Given this list of marker genes Tnf, Ngfr, Tnfrsf10b, Ngf, Tnfrsf11a, Eda2r, Fas, Tnfrsf18, Tnfrsf4 (tumor necrosis factor receptor superfamily, member 4), Nradd, Eda, Tnfrsf1a, Hspa1a, Tnfrsf1b, here is a description of the gene set: species: Mus musculus Mouse Gene Set: GOMF_DEATH_RECEPTOR_ACTIVITY Combining with an extracellular messenger (called a death ligand), and transmitting the signal from one side of the plasma membrane to the other to initiate apoptotic or necrotic cell death.